Given this list of marker genes Pfn1, Ly6d, Lima1, Wfdc17, Pirb, Tmsb10, Rap2b, Gnai2, Cfl1, S100a4, Ifitm2, Arpc1b, Fgr, Fabp5 (NCBI Gene Id 16592), Igkc, Tspo (NCBI Gene Id 12257), Gpr183, Tle3, Nsa2 (NSA2 ribosome biogenesis homolog), here is a description of the gene set: from publication Cui A, Huang T, Li S, Ma A, Pérez JL, Sander C, Keskin DB, Wu CJ, Fraenkel E, Hacohen N (PMID 38057668) Cytokines mediate cell-cell communication in the immune system and represent important therapeutic targets. A myriad of studies have highlighted their central role in immune function, yet we lack a global view of the cellular responses of each immune cell type to each cytokine. To address this gap, the authors created the Immune Dictionary, a compendium of single-cell transcriptomic profiles of more than 17 immune cell types in response to each of 86 cytokines (>1,400 cytokine-cell type combinations) in mouse lymph nodes in vivo. A cytokine-centric view of the dictionary revealed that most cytokines induce highly cell-type-specific responses. For example, the inflammatory cytokine interleukin-1β induces distinct gene programmes in almost every cell type. A cell-type-centric view of the dictionary identified more than 66 cytokine-driven cellular polarization states across immune cell types, including previously uncharacterized states such as an interleukin-18-induced polyfunctional natural killer cell state. species: Mus musculus Genes positively differentially expressed in cell type: MigDC (migratory dendritic cell) upon treatment with cytokine: IL-10 in mouse lymph nodes in vivo. Mouse Gene Set: CUI_MIGDC_IL10_RESPONSE_UP